Given this list of marker genes CDC34 (cell division cycle 34, ubiqiutin conjugating enzyme), PLEKHG6, NEK3, STX3, ZNF280B, UGCG, SENP5, AIFM1, TTL, CEMIP2, FIGNL2, ABHD17C, RGS6, GDF6, WDR37, PEG10, IGF2BP3, E2F6, DPP6, KCNC2, ASAP1, KIAA0930, BEND4, CCDC71L, CNTRL, NPHP3, NLRP2B, ANKRA2, AEN, PARPBP, KLHL6, LAMP2, C14orf28, DNAAF9, OPA3, RDX, POGZ, HOXD1, MEF2C, OSBPL3, TTLL4, PRRX1, ERCC4, MASP1, B4GAT1, FASLG, TMEM65, PDP2, PLXNA4, ZNF587, DDX19A, A1CF, ZNF512B, PIK3IP1, PBX2, LRTOMT, DTX4 (NCBI Gene Id 23220), GAS7, TRIB1, COL27A1, SMAP1 (NCBI Gene Id 648324), IGF2BP1, SALL3, FAM135A, IKZF2, ABCB9, DICER1, TAF9B, ELP1, SIGLEC14, PIGA (phosphatidylinositol glycan anchor biosynthesis class A), USP38, AP1S1, POLR3D, UTRN, PLA2G3, ATP8B4, SMC1A, TXLNA, PLXNC1, TBKBP1, SLC31A2, MAP3K2, AMT, RAB11FIP4, DHX57, TGFBR3, CD200R1, MMS22L, HMGA1, ADGRL3, TGFBR1, ADRB1 (NCBI Gene Id 153), CLDN12, LPGAT1, POGLUT1, SLC25A24, SLF2, RUFY3, BACH1, CDKN1A, AK3, IMPG2, SALL4, HAS2, RAB8B, LIPT2, NHLRC3, ZNF689, PLPP6, IGF1R, ERO1A, ITGB3, AHCTF1, PCGF3, HIF3A, CADM2, HDLBP, ARHGAP28, PARM1, ARK2C, EPHA4, BSN, GOLGA6L4, STXBP5, MSN, GAN, BZW1, XK, ZNF784, ZFYVE26, CLP1, SEMA3F, STARD13, FZD4, TSEN34, NR6A1, CBX2 (chromobox 2), INSR, FRMD4B (NCBI Gene Id 23150), MTDH, TSPEAR, KIAA1958, GALNT1, ZNF341, PRDM5, PLPP5, PAPPA, EFHD2, LIPH, COL5A2, LRIG2, GJC1, ARL5A, PLXND1, CLASP2, LRFN4, PLD3, ENTPD7, STARD3NL, CNOT6L, TECPR2, XKR8, ATOSB, ADAMTS15, PCDH19, RAB15, IRS2, NPEPL1, HMGA2, WDFY3, XYLT1, KLF8 (NCBI Gene Id 11279), LIN28B, GPX7, MIB1, PITPNM3, SPRYD4, ERCC6, PRTG, RGS16, RSPO2, COL4A6, ONECUT2 (NCBI Gene Id 9480), C19orf47, SDR42E1, MAP3K1, PRKAR2A, KLHDC8B, PXDN, ARHGEF38, FZD3, TMOD2, ADAMTS8, CRTAM, LIMD2, NRAS, AMOT, IGF1, FNDC3B, MED28 (NCBI Gene Id 80306), CARNMT1, THOC2, MAPK8, AGO4, SNX16, CCL7, ABT1, TMPRSS2, DUSP1, TMEM167A, SLC5A9, SLK, YPEL2, TRIM67, GATM, MAP3K9, TSC22D2, FIGN, PRPF38B, VCF1, GDPD1, SMIM3, DNA2, ANKRD52, SNX30, PDPR, KCNQ4, YOD1, MBD2, ESR2, GCNT4, BIN3, PPP1R15B, AGAP1, ARHGEF15, TMEM234, DTX2, ARID3A, HIP1, FNIP1, SMARCAD1, COL4A2, USP32, ADRB2, SCN4B, KCTD21, PLEKHA8, ZBTB10, SCN5A, SEMA4C, PARD6B, DDX19B, NAT8L, CCND2, TRIM71, DCAF15, SMUG1, CPEB1, GABBR2, HOXA9, NME6 (NME/NM23 nucleoside diphosphate kinase 6), GALNT15, MFSD4A, KCNJ11, RFX6, CERT1, GYG2, GOLT1B, GRAMD2B, HIF1AN, CCNT2, AMER3, CRB2, IFI44L, DDI2, SKIL, PGM2L1, ZBTB8B, GNPTAB, ACSL6, DCUN1D3, LRIG3, ENTREP2, C15orf39, CLDN16, DVL3, RALB, TNFRSF1B, EIF4G2, PLEKHO1, LBR, SLC66A1, AMMECR1L, INTS6L, CCR7, CDC25A, ZSWIM5, IL10, CD59, RNF44, FGF11, ADRB3, DDTL, CEP120, CASP3, SIGMAR1, MYCN, XRN1, ZNF322, RASGRP1, KDM3A, NAP1L1, ARMT1, STK24, KLHL31, IGDCC4, ZNF652, TMPPE, SLC25A18, DNAJA2, MEIS2, PARP8, RICTOR (NCBI Gene Id 253260), RBFOX2, PALD1, NYNRIN, HSPA14, ABL2, VAV3, FBXL12, GXYLT1, RAB3GAP2, PXT1, PBX1, IGF2BP2 (NCBI Gene Id 10644), STRBP (spermatid perinuclear RNA binding protein), RANBP2, SCN11A, ZNF644, SRGAP1, USP44, DIP2A, MARS2, FGD6, PRSS22, ADAMTS6, KCTD17, C18orf21, STK40, PDE12, PLAGL2, COIL, TMEM121B, THRSP, ACVR1C, AFF2, CRCT1, ZCCHC9, COL4A1, STIMATE, GFM2, CHIC1, FBXO30, ACTA1, CACNB4, TRMT13, ACVR2A, CUX1, VSNL1, INTS2, NOL4L, TXLNG, EEA1, ZNF275, COL1A2, MAP4K3, DLST, SLC20A1, AKAP6, MTRES1, SDK1, CBX5, CD164, LINGO1, HOXA1 (NCBI Gene Id 3198), FAXC, ZNF516, MTUS1, ARG2, CANT1, CERCAM, POLL, EIF2S2, CCNJ, RCN1, SUB1, VIRMA, FOXP2, PTPRD, CEP135, GALNT2, MRS2, HDX, ZBTB5, SIGLEC5, SEMA4G, MDM4, TMC7, EDEM3, GALC, PRLR (NCBI Gene Id 5618), TET3, COL3A1, CPEB3, EEF2K, CHD4, PABIR1, KATNAL1, LEPROTL1, GGA3, SESTD1, GPR26, TRABD, CLCN5, FMO4, DNAJC1, NGF, RBMS1, PKD1L2, SLC25A27, MOB4, SFMBT1, GPCPD1, PBX3, E2F5, RBMS2, SLC30A4, PPP1R16B, ZBP1, FNDC3A, DUSP22, NME4, TRIM41, NKAPD1, ZNF10, CPA4, TREML1, PCDH20, RIMOC1, ATP2A2, SLC5A6, KLF9, BEGAIN, STARD9, IL13, ZNF710, CPEB2, LIN28A, DLC1, ATL2, EDN1, GNG5, GTF2I, APBB3, DPH3, SLC22A23, GRPEL2, IQCB1, ACER2, PGRMC1, SCD, DPP3, PEX11B, DDX31, SLC2A12, PTAFR, NIPAL4, SRD5A3, SENP2, E2F2, GPATCH2, USP24, RNF20, HOOK1, SLC35D2, IGDCC3, UHRF2, OSMR, ARID3B, FNIP2, HIC2, PPARGC1B, SLC38A9, HAND1, MED8, SOCS4, GALE, WNT9B, FRAS1 (NCBI Gene Id 84949), ZBTB39, MAPK6, SMARCC1, SLC16A9, SERF2, TNFSF9, ERVH48-1, GPAT4, TRANK1, ELF4, DMD, MSR1, C8orf58, ZNF583 (NCBI Gene Id 147949), DCUN1D2 (defective in cullin neddylation 1 domain containing 2), SLC10A7, HECTD2, ABCC5, B3GNT7, here is a description of the gene set: from publication Chen Y, Wang X (PMID 31504780) Human Gene Set: MIR4500 Genes predicted to be targets of miRBase v22 microRNA hsa-miR-4500 in miRDB v6.0 with MirTarget v4 prediction scores > 80 (high confidence targets). studied in species Homo sapiens